Given this list of marker genes ARHGAP44, NF1, TIAM1, HACD3, RHOU (ras homolog family member U), DOCK5, FARP1, DOCK7, SH3BP1, WASF1, CRKL, CDKL5, ELMO1, AIF1, LRP4, PIK3CB, KRAS, DBNL, KBTBD7, OGT (NCBI Gene Id 8473), CRK, CADM4, GARRE1, CCL19, CDH13, SSX2IP, RTN4, NISCH, RHOG, RAC3 (Rac family small GTPase 3), ABI2, GABARAP, STMN3, AUTS2 (NCBI Gene Id 26053), ARHGAP24, EPS8, HACE1, FARP2, ARHGAP17, RAC1, CYFIP1, FNTA, MIR29B1, ALS2, NCKAP1, CCR7 (C-C motif chemokine receptor 7), WASF2, ARF6, DOK7, BRK1, RASGRF1, TEK, TNS3, MIR21, KBTBD6, PIK3CG, here is a description of the gene set: studied in species Homo sapiens Human Gene Set: GOBP_RAC_PROTEIN_SIGNAL_TRANSDUCTION An intracellular signaling cassette in which a small monomeric GTPase of the Rac subfamily relays a signal.